Given this list of marker genes HLA-DRB1, CCL25, PSMB9 (NCBI Gene Id 92051), FAT4, ADAM5, LINC01904, APOBEC3C, BLID, IGHG1, ARHGEF26-AS1 (NCBI Gene Id 100507524), ARFIP2, AP4S1, PCLAF, KRT2, ENSG00000224715, ZNF280A, AURKC, MOBP, SLC17A8, SLITRK2, PTPRF, KRTAP4-12, GBP1, LINC00930, IL20RB, FAM219A, TRAF4, PUS3, CCDC157 (coiled-coil domain containing 157), HSH2D (NCBI Gene Id 84941), HTR3A, SLC8A1-AS1, DYNC1H1 (dynein cytoplasmic 1 heavy chain 1), PTP4A3 (NCBI Gene Id 11156), DUXAP9, NEUROD2 (neuronal differentiation 2), ZNF239, HGD, NLRC5, HCAR3, CCN4, TUBA4B, HNRNPA3P1, RBCK1, RNF24, DOK5, RTCB, ARHGEF34P, ARHGAP45, NHLH1, AGPAT3, CAPSL, GSDMD, ENSG00000284837, TMEM253, KRT82, LINC00957, CTLA4, PLAAT4, NLRP8, TXNDC11, HLA-DOB, AK8, PCDH17, RNF114, DTL, PLEKHO1, SPTA1, LINC00309, ARL5C, DMRTB1, MMRN2, ACSS3, HLA-A, TRAFD1, MCF2L2, FGFR2, SH3GL1, SLC10A1, GIMAP8, GPR143, GNRHR2, IQCH, HNRNPA1L2, STAT1, SLC7A3, TSPAN7, RBFOX2, TNF, MVD, ACSBG2, VWDE, KLLN, IL18BP, CA14, VPS9D1, PSMB8, DUSP8, OCA2 (OCA2 melanosomal transmembrane protein), DDX39A, PATE2, CXorf58, USP30-AS1, IGFL1, VTCN1, APOL1, ATXN3L, CERCAM, CBX6, LAMA1 (NCBI Gene Id 3907), APOL2, MAS1L, GMPPA, CAVIN3, LRP4, PLAT, NOMO3, GPX2, GNAO1 (NCBI Gene Id 2775), HLA-DPB1, BACE1, PTTG1, HLA-DRB6, PCYOX1L, IL12RB1, PSME2, CLDN4, USH1C, RAB6B, UPB1, HAPSTR2 (NCBI Gene Id 389895), PCDHGB5 (NCBI Gene Id 56101), ZNF572, LOXL1-AS1, FAM241B, RPL13AP17, DNPEP, ELF4, ZNF568, CALHM6, NOSTRIN, HULC, PIM3, ARSL, EPB42, ABI3, DGKI, BAK1, PAK3, HAS2, MYB, ZNFX1, HYOU1, ENSG00000230725, VN1R3, OXCT1, POTEM (POTE ankyrin domain family member M), TRIM56, FAP, CACNA2D1, SND1, ZNF705G, LINC00029, KIR2DS3, RNFT2, ZNF287, MAP10, NIFK-AS1 (NCBI Gene Id 254128), PTPN3, LUZP2, ZNF202, GHRH, DNAH10, BTN3A1, PCYT2, SNORA17B, ZNF280B, ENKUR, EXT1, SMIM24, DNAJC1, IGF2BP3, CIMIP5, KEAP1, SPRYD3, ESCO2, SECTM1, HOXB-AS3, SPAM1, SIGLEC6, WARS1, TMEM214, here is a description of the gene set: Genes down-regulated in D10.G4.1 T cell line (12h): control versus treated with NMU. Effects of Neuromedin-U on gene expression in mouse D10.G4.1 T-cells natively expressing the GPCR Axor13 Human Gene Set: GSE1791_CTRL_VS_NEUROMEDINU_IN_T_CELL_LINE_12H_DN studied in species Homo sapiens from publication Johnson EN, Appelbaum ER, Carpenter DC, Cox RF, Disa J, Foley JJ, Ghosh SK, Naselsky DP, Pullen MA, Sarau HM, Scheff SR, Steplewski KM, Zaks-Zilberman M, Aiyar N (PMID 15585845)